Given this list of marker genes Slc25a44, Mcm5, Sema6d, Oprd1, Gm4894, Tkfc, Bltp2, Plcxd1, Gm12887, Hecw1, Tmem86b, Nrg3, Nsun5, Ntng1, Etv5, Rc3h1, Gbp6, Dynlt5, Kmo, Gpx3, Zfp735, Gprin1, Dpp8, Smarcad1, Pappa, Tnrc6b, Isl1, Stox2, Psd3, Prkag2, Cenpw, Trim24, Slc35f2, 3425401B19Rik, Myl9, Slc5a7, Ppp1r1b, Syt5, Ptpro, Rfc5, Gigyf1, Mpv17l, Nhsl2, Ttc17, Tspan7, Tulp1, Rtf1, Gbp4, Vps26c, Fgf13, Wtap, Wnt9a, Kcp, Csn2, Pacs1, Asap2, Eps8l3, Capn7 (calpain 7), Mrpl3, Nipsnap2, Rab11fip1, Gm12886, Bclaf3, Nrbp1, B3gnt5, Sema4b (NCBI Gene Id 20352), Ctps2, Stc1, Hdgfl1, Hspa12b, Rph3al, Rps6, Ssbp2, here is a description of the gene set: Mouse Gene Set: MIR_6961_5P Genes predicted to be targets of miRBase v22 microRNA mmu_miR_6961_5p in miRDB v6.0 with MirTarget v4 prediction scores > 80 (high confidence targets). studied in species Mus musculus from publication Chen Y, Wang X (PMID 31504780)